Given this list of marker genes TSC1, FRMD4B, ARL5A, MAP4K5, OSBPL1A, MGAT4B, GALNT4, BMP1, ACVR1B, LTF, ARFRP1, FGD2, KLRD1, LGALS8, IL18, HLA-DRB1, PCTP, NAAA, THEMIS2, IL18R1, SPECC1, ITSN1, PRMT2, TAL1, DENND5A, PHF20, DIP2B, INPP4A, TSPAN1, FAM114A1, TRIO, FLT3, CCND1, RPGRIP1 (NCBI Gene Id 57096), CBFA2T3, ADGRL4, LY86, RASA2 (NCBI Gene Id 5922), TRIT1 (tRNA isopentenyltransferase 1), RFLNB, SLC25A53, GLIS2, IRAK4, HOXA11-AS, DKKL1, DNAJB9, LBP, ACVR2A, PRKCE, MSL2, IRF6, RAB3GAP2, KMO, HCK, BCL11A, PAFAH2, ABCA1, CD300A, GGT5, HLTF, PTPN12, MAN2B1, PDGFRB, STK17B, ST6GAL1, ALDH6A1, RAB14, TMPRSS3, AKNA, VAPB, SPRY2, GNA15, HAAO, NFKBIA, TENT5C, GIMAP6, MAST3, PTPRE, S100A4, ICAM1 (NCBI Gene Id 3383), NCF1, ITGAX, ZNF768 (zinc finger protein 768), GRN, SLC28A2, DDX4, GAB1, RSAD2, TYROBP, ST14, CIPC, DSTYK (dual serine/threonine and tyrosine protein kinase), CCDC28A (NCBI Gene Id 25901), CDH17, CAMK1D, GATM, ST3GAL5, PITPNC1, CA9, RGS2 (NCBI Gene Id 5997), KDM7A, TSC22D1, PEX11A, RAB43, GPM6B, ARHGEF18, FAM107B, ROBO1, ABHD5, NHSL3, SH2B3, MEIS1, SASH1, POLDIP3, CABLES1, WDFY2, ST3GAL2, P2RY14, RAMP2, EEIG1, PPFIBP2, PIP4K2A, AFF4, MAP3K8, CYB5R3, SLCO3A1 (solute carrier organic anion transporter family member 3A1), RCN3, PRDM5, CYP4V2, MMP2, ITGAV, NEK6, DDHD2, LPCAT1 (lysophosphatidylcholine acyltransferase 1), CEP68, ZNF436, SPOP, ANGEL1, PAK1, KLF7, MICAL1, HLA-E, SLC52A3, PLAUR, ZNF821, ZFHX3, SELENBP1, CD52, PLBD1, SEZ6L, BNIP2, MYADM, EIF4B, ABHD4, CEACAM21, FES, TP53BP1, S100A6 (NCBI Gene Id 6277), SPAG1, GRAMD1A, AQP9, IRF8 (interferon regulatory factor 8), FHOD3, ANXA4, CSF1R, TMBIM1, TWIST2, GON4L, CTSG, FBLIM1, DCXR, GDPD5, CPPED1, CTSS, EBI3 (Epstein-Barr virus induced 3), APBB2, C11orf54, GNB4 (NCBI Gene Id 59345), RTP4, MAPRE2, SEC61A1, DGLUCY, TCEAL1, CTDSPL, LTBP3, CRYZL1, RBM43, LMO2 (LIM domain only 2), PLAAT3, HLA-DOB, GEM, GNA14, IL1R2, DNER, EPB41L3, CD81, B4GALT6, NIBAN2, CRIPTO, LHPP, here is a description of the gene set: Genes up-regulated in comparison of adult thymic progenitors versus adult DN3 thymocytes. Development of T-cells provides a unique opportunity to study cell-fate determination due to the accessability and the well defined stages of developmental stages. In order to understand the genetic programs underlying fetal and adult T‑cell fate specification we subjected highly purified fetal and adult T-cell progenitor populations to a genome‑wide transcriptional analysis. The aim was to identify molecular elements that govern T-cell fate specification as a whole but ultimately to isolate elements that were specific for a given population in a specific developmental window. studied in species Homo sapiens Human Gene Set: GSE24142_EARLY_THYMIC_PROGENITOR_VS_DN3_THYMOCYTE_ADULT_UP from publication Belyaev NN, Biró J, Athanasakis D, Fernandez-Reyes D, Potocnik AJ (PMID 22581009)